Given this list of marker genes Alox12, Alox5ap, Ltc4s, here is a description of the gene set: This event has been computationally inferred from an event that has been demonstrated in another species.<p>The inference is based on the homology mapping from PANTHER. Briefly, reactions for which all involved PhysicalEntities (in input, output and catalyst) have a mapped orthologue/paralogue (for complexes at least 75% of components must have a mapping) are inferred to the other species. Reactome Pathway: Biosynthesis of Lipoxins (LX) electronically inferred by orthology from the curated human pathway part of: Biosynthesis of specialized proresolving mediators (SPMs) species: Mus musculus